The following is a description of a gene set: Genes negatively differentially expressed in cell type: γδ T cell upon treatment with cytokine: LIF in mouse lymph nodes in vivo. studied in species Mus musculus Mouse Gene Set: CUI_T_CELL_GD_LIF_RESPONSE_DN Cytokines mediate cell-cell communication in the immune system and represent important therapeutic targets. A myriad of studies have highlighted their central role in immune function, yet we lack a global view of the cellular responses of each immune cell type to each cytokine. To address this gap, the authors created the Immune Dictionary, a compendium of single-cell transcriptomic profiles of more than 17 immune cell types in response to each of 86 cytokines (>1,400 cytokine-cell type combinations) in mouse lymph nodes in vivo. A cytokine-centric view of the dictionary revealed that most cytokines induce highly cell-type-specific responses. For example, the inflammatory cytokine interleukin-1β induces distinct gene programmes in almost every cell type. A cell-type-centric view of the dictionary identified more than 66 cytokine-driven cellular polarization states across immune cell types, including previously uncharacterized states such as an interleukin-18-induced polyfunctional natural killer cell state. from publication Cui A, Huang T, Li S, Ma A, Pérez JL, Sander C, Keskin DB, Wu CJ, Fraenkel E, Hacohen N (PMID 38057668), and this is the list of marker genes: Jund, Hspa8, Junb, Hspa1b, Dnaja1